The following is a description of a gene set: This event has been computationally inferred from an event that has been demonstrated in another species.<p>The inference is based on the homology mapping from PANTHER. Briefly, reactions for which all involved PhysicalEntities (in input, output and catalyst) have a mapped orthologue/paralogue (for complexes at least 75% of components must have a mapping) are inferred to the other species. electronically inferred by orthology from the curated human pathway studied in species Mus musculus Reactome Pathway: Synthesis of diphthamide-EEF2 part of: Gamma carboxylation, hypusinylation, hydroxylation, and arylsulfatase activation, and this is the list of marker genes: Dnajc24 (DnaJ heat shock protein family (Hsp40) member C24), Dph2, Eef2, Dph6